The following is a description of a gene set: studied in species Homo sapiens Human Gene Set: GOMF_EXTRACELLULAR_MATRIX_CONSTITUENT_CONFERRING_ELASTICITY A component of the extracellular matrix that enables the matrix to recoil after transient stretching., and this is the list of marker genes: FBN2, EMILIN1, FBLN5, ELN, EMILIN2, FBN1, EMILIN3, FBLN2, LAMC1